Given this list of marker genes EBI3, ARG1, CBFB, EMILIN2, LGALS9B, SMARCA4, CXCL13, CD160, CD44, CCR7, LGALS8, NCKAP1L, TNFRSF14, HSPD1, CD1D, PLPP3, SELE, CD55, CD27, HLA-DPA1, IL7, PIK3CD, HLA-E, IL2, FLOT2, FADD, CD9, CD5, CEACAM1, YTHDF2, VEGFA, CELSR2, PPM1F, SDC4, DHPS, RAG1, RIPOR2, ARID1B, CRTAM, IL1A, GTPBP4, SMARCC2, ICOS, PHF10, DNAJA3, KLRK1, CCL2, SIRPG, BMI1, CEBPB, PTPRR, IGFBP2, ANXA1, ITCH, RAP1GAP, FOXA1, FUT4, MFSD2B, LGALS1, LGALS3, MDK, IL4R, TMX1, PTPRC, IL12A, C1QTNF1, HLA-DRA, NDFIP1, HLA-DRB4, ACTL6A, KLRC4-KLRK1, PLA2G5, HLA-G, ZP4 (NCBI Gene Id 57829), CD83, ETS1, HLA-DRB5, FOXJ1, LEF1, HLA-DQA1, ZC3H8, MEGF10, SMAD7 (SMAD family member 7), METTL3, BRD4 (NCBI Gene Id 90616), CD47, SELENOK, NEXMIF (neurite extension and migration factor), PKP1, IRAK1, IL6, TSPAN32, PCK1, YWHAG (tyrosine 3-monooxygenase/tryptophan 5-monooxygenase activation protein gamma), GATA3, WNK1, SRC, LOXL3, TGFB1, CD69, AP3B1, SERPINE2, EFNB2, VSIR, CEACAM6, ZP3, RNASE10, ERBB2, CDKN2A, CCL19, PCDH8, LCK, SASH3, BMP7, BMP2, IL6R, PRKCA, LAG3, FGA (NCBI Gene Id 2243), ADAM19, BRD7, HLA-DRB1, NR4A3, JAK3, PKHD1, ITGA4, HLA-DRB3, CORO1A, ZBTB1, SOX13, PTK2, SCRIB, ADAMTS18, BMP6, HLA-DQB1, UFL1, CD209, SPECC1L, PRKCD, CDH1, CLECL1P, AMBRA1, CXCL12, PNP, ADGRG1, HLA-DQA2, FSTL3, XBP1, KLF4, MMRN1, DLG5, FUT9, TESPA1, FGG, STAT5B (signal transducer and activator of transcription 5B), KAT5, DAPL1, RAG2, IL10, CD274, TNF, MAP2K5, RELA, NRARP, DUSP3, TNR, ZMIZ1, EFNB3, NR5A2 (NCBI Gene Id 8768), CD40LG, CHST2, MIRLET7E, IL4, MDGA1, CD80, WNT5A, HAVCR2, RPS3, ACTL6B, PTPN11, RHOA, GPR65, SMARCA2, CASP3 (caspase 3), DENND6A, TNFSF14, MBP, ANK3, HLX, SFTPD, IL21 (interleukin 21), CD86, SH2B3, HES1, ABL2, GPAM, IL2RG, MALT1, SCGB1A1, CCDC88B, ILDR2, PAG1, CD4, SHH, IL12B, PRKAA1, LAPTM5, CSK, NLRP3, HLA-DOB, PLA2G2F, CELA2A, ZAP70, TYK2, TNFRSF21, PDPN, ARID2, LAX1, FYN, EPHB3, NKAP, PKP3, CLEC4G, PTPN2, CD70, RARA, THY1, IL20RB, NODAL (NCBI Gene Id 8114), FLOT1, HFE, LEP, GLI2, RUNX3, CD46, TMIGD2, FUT7, PPARA, TRAF6, RHOH, SMARCC1, EPCAM, RIPK2, NF2, GP6, CARD11 (caspase recruitment domain family member 11), PTPN6, XCL1, GCNT2, BTNL2, SOX2, RUNX1, TRPV4, BTN2A2, IL1RN (interleukin 1 receptor antagonist), PLG, NFAT5, CHST4, MAP2K1, IFNL1, SPN, TWSG1, HMGB1, MAP3K8, DPP4, MIR31, VTCN1, FOXA2, SKAP1, HSPH1, BCL10, NOTCH1, ZBTB7B, EMILIN1, IGF1, LGALS9C, PODXL, CD81, BMP4 (NCBI Gene Id 652), PRKG1, PRDX2, PDPK1, NCK2 (NCBI Gene Id 8440), EGR3, HLA-DMB, SLAMF1, ICOSLG, IL4I1, SYK (spleen associated tyrosine kinase), SMARCD3, IFNG, BAD, EPO (NCBI Gene Id 82670), MAD2L2, TBX21, PTPRG, CCR2, SART1, LGALS9, IL23A, VAV1, HTR2A, CD276, CTLA4 (cytotoxic T-lymphocyte associated protein 4), TENM3, FGL2, RDX, GCNT1, WNT4, TNFSF4, MIR21, DTX1, MIR125A, CD74, PRKCZ, TNFAIP8L2, PAWR, IFNB1, NOD2, MIR146A, CCL28, ARG2, MUC21, IL6ST, MAD1L1, WNT10B, SMARCD1, PIEZO1 (piezo type mechanosensitive ion channel component 1 (Er blood group)), NCK1, VPS33B, TNFSF9, TGFBR2, CD3E, ADA, DOCK8, AP3D1, DUSP22, AFDN (NCBI Gene Id 92217), GLMN, AGER, FERMT3, IDO1, HLA-A, LILRB1, OPA1, HLA-DMA, TIGIT, RC3H2, PRNP, PLA2G2A, WNT1, SOX12, AKT1, CD300A, MAGI1, IL18, KLHL25, EP300 (NCBI Gene Id 2033), CYRIB, MAPK7, IFNA2, APOA1, EFNA5, UBASH3B, FCHO1 (FCH and mu domain containing endocytic adaptor 1), CD6, HTN1, TARM1, PYCARD, PDCD1, SPINT2, PTPN23, PPP3CA, IL7R, CCL5 (C-C motif chemokine ligand 5), ADTRP, PIK3R6, LILRB4, LRRC32, SERPINF2, HLA-DOA, CX3CL1, RASAL3, ZDHHC21, MARCHF7, ALOX5 (NCBI Gene Id 240), LILRB2, HHLA2, ITPKB, NFKBIZ, ASCL2, CD28, PRKCQ, GPNMB, NOTCH4, F11R, ARID1A, MIRLET7G, EPHA7, TNFSF13B (NCBI Gene Id 89794), SMARCB1, RGCC, JAK1, ELANE, SELP, KIFAP3, SPTA1, FGL1, MIA3, KIF26B, SOCS5, SHB, TFRC, MIR30B, FOXP3, FBXO38, IL2RA, CCL25, SMARCD2, MIR27A, AKNA, IL36B, PLA2G2D, PRKAR1A, RC3H1, STAT5A, PBRM1, ITGB2, MINK1, JAG1 (jagged canonical Notch ligand 1), MAPK14, SOCS1, MIR221, ALOX12, EPB41L5, BCL6, FGB, MIR181C, CR1, VNN1, ZBTB16, ST3GAL4, SOCS6, SIRPA, DLG1, HLA-DPB1, IL15, CTSG, TNFRSF13C, HAS2 (hyaluronan synthase 2), TNFSF11, IL1B, TMEM131L, YES1, PLAUR, ADIPOQ, PTPRU, SLC4A2, VSIG4 (V-set and immunoglobulin domain containing 4), IL1RL2, CYLD, IRF1, KLHL22, SFN, MYADM, BTLA, CTNNB1, KITLG, MYO10, PDCD1LG2, MIR222, GNRH1, CAV1, TJP1, RASGRP1 (RAS guanyl releasing protein 1), PELI1, ADAM8, CITED2, MTOR, LYN, WNT3A, SPI1, MIR92A1, FOXO3 (forkhead box O3), SOX4 (NCBI Gene Id 6659), ASS1, BRD2 (bromodomain containing 2), HLA-DQB2, SLC7A1, CD37, EFNB1, CBLB, SWAP70, VCAM1, IL23R, ADORA2A, IGF2 (insulin like growth factor 2), FXYD5, ACTB, ZC3H12A, ABL1, CDSN, DUSP10 (dual specificity phosphatase 10), B4GALNT2, AIF1, GLI3, B2M, FUT3, CCL21, MIR141, IL12RB1, PTPN22, LRFN3, TNFSF18, CD24, JAK2, ZNF703, ZDHHC2 (zinc finger DHHC-type palmitoyltransferase 2), SMARCE1, SIRPB1, IHH, NFKBID, ABCA12, here is a description of the gene set: species: Homo sapiens Any process that modulates the frequency, rate or extent of attachment of a cell to another cell. Human Gene Set: GOBP_REGULATION_OF_CELL_CELL_ADHESION